The following is a description of a gene set: Human Gene Set: ATF5_TARGET_GENES studied in species Homo sapiens Genes containing one or more binding sites for (ATF5) in their promoter regions (TSS -1000,+100 bp) as identified by GTRD version 20.06 ChIP-seq harmonization. from publication Yevshin I, Sharipov R, Kolmykov S, Kondrakhin Y, Kolpakov F (PMID 30445619), and this is the list of marker genes: NOP10, VIPAS39, ARPC4, ESYT1, DCAKD, EIF3B, SLC4A1AP, CASD1, H2AC25, DPY30, ADD3, PCDH12, LINC02331, HOXB6, H2BC15, PNLIPRP1, LINC01767, TTLL13, LINC02756, SNORD26, CLDN12, TMEM260, METTL21A, SCUBE2, TXNRD1, DLGAP1-AS2, NMT1, RBM23, ZNF473, ST7-OT4, IL20RA, TACC2, TTC9C, ODAD3, TSPAN12, H2BC7, ANG, GET1, BOD1, HSPH1, C1orf174, SCP2, HOXA9, AHR, NSA2, LSG1, NFS1, PPP4R3B, RNU5D-1, UQCRH, PNRC2, GMEB1, CDKL3, H2BC14, PAQR3, AZIN1, CLHC1, HSPE1, EGF, ZNF217, MRPL15, ILF2, TMEM167A, PRMT5-AS1, RNU6-9, PRR5L, LRRC41, CNPY4, BZW2, CDH17, LINC02474, ACAP2, APOH, PWWP3A, SRI, STAMBP, NUCKS1, TNPO1, MARF1, RNA5SP21, PSME2P3 (proteasome activator subunit 2 pseudogene 3), TAF12, MACC1, SNORD18A, MAP3K1, H2AC7, H4C13, DNAI4, SNORA63B, PRMT9, HSPD1, LINC02823, EXOSC7, UBE2B, ARL14EP, ERCC1, RHOT1, SUGT1-DT, ST7, MRPL51, NDUFS4, MRPL20-DT, EIF2S1, NT5C3A, ITFG1 (NCBI Gene Id 81533), RPA3, ANAPC7, HNRNPUL2, RTN4 (reticulon 4), CCT5, ITK, PJA2, PKN2-AS1, MTERF1, SELENOW, COQ5, NDE1, SUGT1, CCDC117, USF1, NKAPD1, MYL12B, SNORD16, ENSG00000266401, H2BC26, HNRNPUL2-BSCL2, BLOC1S6, DNAAF10 (dynein axonemal assembly factor 10), PLS1, PPP1CB, ARID1A, ZZZ3, RNASE4, MYOF, SLC12A2, SINHCAF, ATP10B, MCU, TRIM41, LINC01806, TRIM5, PRKCI, LINC02832, ST13, CACYBP, TMEM14B, NGRN, VWA8, C5orf52, ALDH3A2, MRPL20, UBB, TCP1, AK2, TM4SF4, ENSG00000247193, RPS15A, NDUFA9, CLNK, GPNMB (glycoprotein nmb), RPS24, ACTR3, GCC2-AS1, H2AC16, VRK2, FAM13A, RNU5E-4P, HNRNPA2B1, CBR4-DT, AP3S2, KDM3A, ABHD17C, PRR13P5, PAPSS2, SLC41A2, ZSWIM8, LEKR1 (leucine, glutamate and lysine rich 1, NCBI Gene Id 389170), TIMELESS, MRPL48, RPS27A, H3C4, EPS15, EPCAM, ZBTB37, SMG8, GAS5, USP32, MRPS27, SPRY1, PHKB, THUMPD3, EFCAB14, TCP11L2, H2BC16P, ATP6V1D, PAXIP1-AS2, MYO1A, GAU1, H2BC5, ATG101 (NCBI Gene Id 95005), MEIS2, R3HDM1, PIH1D2, NEDD4, MAN2C1, DYNC1I2, MEF2C, CENPA (centromere protein A), FAM3D, MED16, GARNL3, SLC7A6, ZRANB3, PAPOLA, ZFC3H1, PPFIBP2, RPL32, ZBED5-AS1, MORC4, LNCTAM34A, CYP51A1, DNAJA1, RCAN1, LINC00938, SSBP1, TECPR2, MIGA1, APTX, ATP13A3, RANGAP1, ITGB5, LSM8, HSPE1-MOB4, ALDOA, TAF6, WEE2-AS1, NSRP1, SARNP, MDM2, NEMP1, BISPR, RPL21, PTCD3, PPP6R1, MORF4L2, H3C10, ZNF638, HAVCR2 (NCBI Gene Id 84868), DYM, PARK7, CMTM7, RNF186-AS1, FAM200A, C4orf19, BCAP29, CHP1, RPL23, SAV1, MPPE1, RNY3, SYS1-DBNDD2, RPS12, MUC13, CSGALNACT1, POC1B (NCBI Gene Id 91413), THAP2, SYS1, MALSU1, CPSF2, NFKB1, USP53, BST2, SNHG1, ACYP2, UBLCP1, CCDC28A, LIMA1, SERPINB5, UGP2, PLEKHA1 (NCBI Gene Id 59338), SMARCAD1-DT, MOCS2-DT, USP8 (NCBI Gene Id 9101), EHF, LSM5, NDUFV2, RSL24D1, YJU2, ANXA2R, SEL1L, WIPF2, HSP90AA1, BTG3-AS1, CCDC28A-AS1, DMXL2, LINC02366, RNU4ATAC, ABHD16A, TRA2B, SLF1, METTL5, SBNO1, GULP1, DNAJB12, CCNA2, STRIP1, MYH9, ZBED5, RABGAP1L, RPL37, SLC30A6-DT, USP3-AS1, EXD1, GIRGL, ANKRD17, POLQ, NCEH1, MED7, ZNF451-AS1, MICU1, ST7L, AKAP3, ZNF484, GEMIN2, FAM47E, SNORD25, SNORD27, MYH9-DT, RBIS, LRIG3, SLC17A5, CHD2, LINC02864, RPL7L1 (NCBI Gene Id 285855), TMEM94, ECPAS, CINP, SNORD72, MRPL18, MFAP1, DSG1-AS1, PRDM1, SNHG8, GOSR1, ARPC4-TTLL3, NLN, ENSG00000236098, NHP2, MTHFS, TMEM183A, RINT1, KLRK1, LINC02983, SPINK5, ATPSCKMT, COQ2, TGFBR2, YWHAZ (NCBI Gene Id 83242), NCAPD2, SMAGP, SWAP70, ENSG00000257746, MVB12A, PDSS1, CHASERR, FNDC3B, AKAP9, ADAMTS7P4, LCOR, ANKRD11, PAIP1, ZNF12, SNX8, DDX21, NUP153, RNU7-3P (RNA, U7 small nuclear 3 pseudogene), KBTBD2, TANK, GRK6, CEP350, TGIF1, CD24, LRRC66, WDR75, CDK17, HIF1AN, H3C6, PCNX4, XPR1, MAML3, BTAF1, NUP93, TMEM209, KDSR, CENATAC, MYBPC1, SUPT7L, NUDCD3, RGS20, LINC01719, AGR2, CEP120, RAD54B, PRKCSH, NEMF, RPPH1, FBXO38, BTF3, RN7SL346P, CLASP1, LNPEP, PDIA4, RNF111, FEZ2, SRBD1, MRM3, COMMD4, SETD5, XPNPEP3, EIF4A2, HERC4, LINC-PINT, SLC3A2, NDUFB1, NUP155, TMED10, GCNT3, FHDC1, SMARCAD1, BCL2L15, STAT1, RAD1, OGDH, NUTM1, AHSA1, NAV3, CRYBG1 (NCBI Gene Id 6763), PPP2R2A, VRK3, CARF, USP54, NUDT4, PRRC1, IGFL4, SRSF11, SBF2, SMIM10L1, TACO1, RNU5F-1, TUBA1B-AS1, PAPOLA-DT, HOXA-AS3 (NCBI Gene Id 285944), SPATS2L, CDKN1B, SLC12A2-DT, SFPQ, FAM169A, SP110, LANCL2, TADA3, PRORP, TTC17, H4C3, C4orf36